The following is a description of a gene set: The directed movement of transferrin into, out of or within a cell, or between cells, by means of some agent such as a transporter or pore. Mouse Gene Set: GOBP_TRANSFERRIN_TRANSPORT studied in species Mus musculus, and this is the list of marker genes: Rep15, Tfr2, Lmtk2, Rab11b, Snx3 (NCBI Gene Id 54198), Tfrc, Dnm2, Arhgap1 (NCBI Gene Id 96949), Cltc, Myo1b